The following is a description of a gene set: Human Gene Set: HP_NEOPLASM_OF_STRIATED_MUSCLE species: Homo sapiens Neoplasm of striated muscle A benign or malignant neoplasm (tumor) originating in striated muscle, either skeletal muscle or cardiac muscle., and this is the list of marker genes: TSC2, PAX3, TSC1, PTCH1, SLC22A18, HRAS, FOXO1, TP53, BUB1B, NBN, CHEK2, KEAP1, MAD1L1, IFNG, MLH1, BUB3, DICER1, BUB1, NF1, CEP57, SOX6, PAX7, MDM2, CDKN2A, TRIP13